The following is a description of a gene set: Human Gene Set: MIKKELSEN_MCV6_ICP_WITH_H3K27ME3 Genes with intermediate-CpG-density promoters (ICP) bearing the tri-methylation mark at H3K27 (H3K27me3) in MCV6 cells (embryonic fibroblasts trapped in a differentiated state). from publication Mikkelsen TS, Hanna J, Zhang X, Ku M, Wernig M, Schorderet P, Bernstein BE, Jaenisch R, Lander ES, Meissner A (PMID 18509334) studied in species Mus musculus Somatic cells can be reprogrammed to a pluripotent state through the ectopic expression of defined transcription factors. Understanding the mechanism and kinetics of this transformation may shed light on the nature of developmental potency and suggest strategies with improved efficiency or safety. Here we report an integrative genomic analysis of reprogramming of mouse fibroblasts and B lymphocytes. Lineage-committed cells show a complex response to the ectopic expression involving induction of genes downstream of individual reprogramming factors. Fully reprogrammed cells show gene expression and epigenetic states that are highly similar to embryonic stem cells. In contrast, stable partially reprogrammed cell lines show reactivation of a distinctive subset of stem-cell-related genes, incomplete repression of lineage-specifying transcription factors, and DNA hypermethylation at pluripotency-related loci. These observations suggest that some cells may become trapped in partially reprogrammed states owing to incomplete repression of transcription factors, and that DNA de-methylation is an inefficient step in the transition to pluripotency. We demonstrate that RNA inhibition of transcription factors can facilitate reprogramming, and that treatment with DNA methyltransferase inhibitors can improve the overall efficiency of the reprogramming process., and this is the list of marker genes: PIK3CD, IFNK, GGT7 (NCBI Gene Id 2686), ACCSL, FGL2, FFAR3, LPO, MOV10L1, LEFTY1, KCNAB1, KCNG4, SOX17, AIPL1, PNOC, NRL, SCN4A, FUT1, ARHGAP9, CUX2 (NCBI Gene Id 23316), PRSS16, CLDN14, PAK6, APC2, OR2B11, ALPI, FGF10, PDYN, OPTC, TFAP2B, ETV2, WNT8B (Wnt family member 8B), PROK1, SHANK2, NCAN, PCDH12, CORO1A, SLC2A10, LINGO4, KRT73, ASB2, SECTM1, TBATA, CD40, CD7, SACS, FNDC9, OR4D2, COL11A2, POU2F2, SPACA7, ISLR2, CHRNB4 (NCBI Gene Id 1143, cholinergic receptor nicotinic beta 4 subunit), GPRC5D, SOX6, TH, RTBDN, ODF1, VTN, PAX5, CHRNG, KCNK10, S100Z, GKN3P, SLC14A1, FAM149A, REN, IQCJ, NKX2-6, BSX, GAS2L2, PVALB, CD177, ASIP, KCNJ5, TNF, ADM2